The following is a description of a gene set: species: Homo sapiens Binding to hemoglobin, an oxygen carrying, conjugated protein containing four heme groups and globin. Human Gene Set: GOMF_HEMOGLOBIN_BINDING, and this is the list of marker genes: HPR, HBD (NCBI Gene Id 3045), HBB, SLC4A1 (solute carrier family 4 member 1 (Diego blood group)), AHSP, HBE1, HP, HBG1, HBG2